The following is a description of a gene set: Human Gene Set: HP_ABNORMAL_PARIETAL_BONE_MORPHOLOGY Abnormal parietal bone morphology studied in species Homo sapiens Any abnormality of the parietal bone of the skull., and this is the list of marker genes: MPDU1, CREBBP, PIGY, PIGL, PGAP3, RUNX2, TWIST1, ZSWIM6, ZIC1, RNU12, PHF21A, POLR3A, ALX4, PPM1D, RPS19 (ribosomal protein S19), FGFR2, PIGW, FGFR3, PTCH1, EXT2, FIG4, PGAP2, VAC14, MSX2, EP300, PIGO, PTPN11, PIGV, KRAS